The following is a description of a gene set: Mouse Gene Set: MIR_1911_5P from publication Chen Y, Wang X (PMID 31504780) Genes predicted to be targets of miRBase v22 microRNA mmu_miR_1911_5p in miRDB v6.0 with MirTarget v4 prediction scores > 80 (high confidence targets). species: Mus musculus, and this is the list of marker genes: Arx, Ing3, Styx, Ppip5k2, Abhd13, Pmpca, Tmem45a2, Fam120a, Luc7l2, Sntb2, Mstn, Adprm, Copb1, Cyp3a13 (NCBI Gene Id 13113), Fbxw7, Phf12, Kcna2, Nlrp12, Fbxo11, Lca5, Nemp1 (NCBI Gene Id 72243), Zc3h4, Rreb1, Med15, Map9, F13b, Actg1, Acsl4, Cyb5r2 (NCBI Gene Id 320635), Cdc23, Ceacam12, Fut8, Samt3, Cnn3, Dhodh, Sppl2a, Dixdc1, Otor, Spry1, Fam118b, Pogz, Dip2c, Syt14, Ston2, Plscr3, Akap6, Csnk1g1, Zfp516, Chsy1, Nampt, Pnma8b (NCBI Gene Id 434128), AW551984, Nmu, Myo18a, Zfp653, Ebf3, Gabpb1, Nr2e1, Myh1, Gnas, Btaf1 (NCBI Gene Id 208902), Zfp626, Pdik1l, Vmn2r37, Kdsr, Cdnf